The following is a description of a gene set: Abnormal periauricular region morphology studied in species Homo sapiens Human Gene Set: HP_ABNORMAL_PERIAURICULAR_REGION_MORPHOLOGY, and this is the list of marker genes: SF3B4, DACT1, CPLX1, PAX1, MID1, TASP1, FGFRL1, WLS, TCOF1, KDR (kinase insert domain receptor), FN1 (fibronectin 1), SNRPN, ZFX, PRMT7, VPS35L, RAB23, CITED2, B3GLCT (beta 3-glucosyltransferase), KRAS, H4C9, SMARCA2, TXNL4A, RAP1B, POLR1C, H4C3, PIGG, LRP5, FGFR2 (fibroblast growth factor receptor 2), GDF1, EIF2AK3, TBX1, XYLT2, EFTUD2, GSC, TMEM260 (transmembrane protein 260), SPECC1L, ZFPM2, SLC4A10, JAG1, EDN1, RERE, DICER1, KMT2D, LETM1, H4C5, SF3B2, CHN1, GATA5, ALX3, POLR1D, GATA4, ANKRD11, ANK1, VPS13B, EDNRA, HK1, DPYSL5, HDAC9, NAA10, FBXO11, PIGS, COL2A1, SIX1, ODC1, PPP1CB, BRF1, FLNB, CRELD1, CTNND2, NPHP3 (NCBI Gene Id 27031), SVBP, ALX1, BCOR, LRP1, GATA6, KDM6A, MED13L, FLNA, AUTS2, PLCB4, UBE3B, GJA5, KIF7, ARID1B, SALL4, SEMA3E, MAFB, MSL3, SEMA5A, HNRNPK, UBE2A, TFAP2A, NSD2, ZNF668, GPC4, IRX5, WBP11, POLR1B, NELFA, KAT6A, STAG2, CTBP1, FGFR1, NKX2-5, SIX5, FGD1, GLI2, ZNF462, CHD7, KCNJ2, HNRNPU, CCDC22, WASHC5, GPC3, EXT2, SALL1, TRPM3, MITF, SYK, GNAI3, MED12, EYA1, FLT4, NKX2-6